The following is a description of a gene set: Genes predicted to be targets of miRBase v22 microRNA mmu_miR_7686_3p in miRDB v6.0 with MirTarget v4 prediction scores > 80 (high confidence targets). from publication Chen Y, Wang X (PMID 31504780) studied in species Mus musculus Mouse Gene Set: MIR_7686_3P, and this is the list of marker genes: Col25a1, Rac1, Fxyd6, Pabpc1, Ptma